Given this list of marker genes Il33, Il15, Ccl21a, Pomt1, Chp1, Igf1, Pomt2, Ccr7, Insr, Pxylp1, Ctnnb1, Ccl19, Soat1, Rab1a, Tcf7l2, Slc2a10, Slc51b, Plcb1, Ramp1, Mustn1, Golga2, Ncstn, Rab1b, Pawr, Ep300, Abca2, here is a description of the gene set: Mouse Gene Set: GOBP_POSITIVE_REGULATION_OF_GLYCOPROTEIN_METABOLIC_PROCESS Any process that activates or increases the frequency, rate or extent of glycoprotein metabolic process. species: Mus musculus